The following is a description of a gene set: Human Gene Set: GOBP_INTERLEUKIN_12_MEDIATED_SIGNALING_PATHWAY studied in species Homo sapiens The series of molecular signals initiated by interleukin-12 binding to its receptor on the surface of a target cell, and ending with the regulation of a downstream cellular process, e.g. transcription., and this is the list of marker genes: IL12RB1, JAK2, TYK2, P4HB, IL12RB2, IL12A, PLCB1, STAT4, IL12B (NCBI Gene Id 7907)